The following is a description of a gene set: Human Gene Set: GOMF_TRNA_SPECIFIC_RIBONUCLEASE_ACTIVITY studied in species Homo sapiens Catalysis of the hydrolysis of phosphodiester bonds in tRNA molecules., and this is the list of marker genes: RPP25, ELAC2, RPP14, POP7, RPP30, POP1, RPP40, TSEN34, RPPH1, POP5, PRORP, ANG, RPP21, ELAC1, TSEN2, POP4, RPP38